The following is a description of a gene set: species: Mus musculus from publication Chen Y, Wang X (PMID 31504780) Genes predicted to be targets of miRBase v22 microRNA mmu_miR_344e_3p in miRDB v6.0 with MirTarget v4 prediction scores > 80 (high confidence targets). Mouse Gene Set: MIR_344E_3P, and this is the list of marker genes: Zfp800, Tent4a, Prkar2b, Zfp644, Sepsecs, Dnal4, AI593442, Socs4, Homer1, Gabpb2, Itga2, Nppc, Cdk17, Spin4, Armc8, Fchsd2, Stard13, F11r, Htr1f, Wapl, Pcdh8, Rc3h2, Cldn10, Ppp1r2, Osbpl6, Numb, Ptbp3, Otx2, Arid5b, Exoc6, Magi3, Clec4d, Wdr44, Bmper, Skil, D16Ertd472e, St8sia4, Kdm6a, Ndfip2, Ets1, Mab21l1, Chic2, Rgmb, Boc, Msi2, Pabpc4l, Ddit4l, Golm2, Rreb1, Adm, Gfpt1, Slc25a42, Cbfb, AI182371, Chml, Zfx, Plpp3, Zbtb41, Dcdc2a, Stk4, Ezr, Bmpr2, Map2, Tent5a, Oxr1, Lrp6, Dlg3, Styx, Tcf7l2, Cobll1, Rc3h1, Lmtk2, Atp8b2, Tmem106b, Plxna2, Nexmif, Prr11, Sp4, Wnt3, Hivep1, Usp33, Smc2, Dock9, 2010106E10Rik, Myh9, Sdr42e1, Jrkl, Wdr82, Cdk13, Serbp1, Ldlrad3, Epb41l2 (NCBI Gene Id 52582), Pgm2l1 (phosphoglucomutase 2-like 1), Vegfa, Gad1, Btf3l4, Blzf1, Tec, Slc37a1, Slc6a14, Nmt1, Wnt5b, Gpr160, Lrp11, Rhag, Spink11, Nr3c1, Usp25, Ermp1, Naa15, Kat6a, Htr5a (5-hydroxytryptamine (serotonin) receptor 5A), Cacnb2, Lcorl, Rp2, Tbx4, C9orf72, Arid2, Kirrel1, Hnf4g, Zbtb44, Rnf138, Pla2g4a, Pcdhb17, Nxpe3, Tmx3, Rock2, B3glct, Erbin, Cnr1, Sh3glb1, Zeb2, Vps26c, Tmem108, Klf6, Tbx5, Caps2, Zbtb34, Hipk3, Fancf, Gpr155, Smad6, Prrx1, Med12, Hace1, Med13, Rora, Rasef, Adcyap1, Aff4, Cdh11, Pip5k1b (NCBI Gene Id 53355), Nrde2, Smarca1, Vat1l, Gucy1a2, Eml1, Pappa2, Zfp712, Smad7, Pde4b, Osbpl3, Fmr1, Pik3ip1, Prkaa1, Zswim6, Pcsk5, Taf7, Ptpn21, Cpeb4, 4921517D22Rik, Fgfr1op2, Slit3, Sp3, Pde4d, Baz2b (NCBI Gene Id 51934), Cdk14, Irak3, Erg, Tnfsf11, Fgf12, Hook3, Pbrm1, Ppp6r1, Ppfibp1, Cd9, Creb5, Srsf11, Fut9, Rere, Sema3e, Orc6, Frzb, Mfn1, Pclaf, Ero1a, Trappc3 (trafficking protein particle complex 3), Gosr1, Tex14, Pcnx1, Trpc5os (NCBI Gene Id 100503240), Ahr, Ripor2, Slc8a1